The following is a description of a gene set: species: Mus musculus Mouse Gene Set: REACTOME_APOPTOTIC_EXECUTION_PHASE Apoptotic execution phase, and this is the list of marker genes: Hmgb1, Clspn, Tjp1, Stk26, Prkcq, H1f5, Rock1, H1f2, Dffb, Dffa, Pkp1 (plakophilin 1), Bmx, Plec, Dsg3, Satb1, Vim, Sorbs2, H1f0, Dsp, Ctnnb1, Sptan1, Casp3, Casp8, Acin1, Mapt, Birc2, Ptk2, Hmgb2, Bcap31, Dsg2, Casp6, Apc, Lmnb1, Stk24, Dsg1a, Add1, Fnta, Gsn, Prkcd, Gas2, Ocln, H1f4, Tjp2, Kpnb1, Kpna1, Lmna, H1f1, Casp7, Dnm1l